Given this list of marker genes OS9, PSMB4 (NCBI Gene Id 5692), PSMD3, PSMB1, PSMD14, ADRM1, UBA52, RNF5, ERLIN2, PSMD12, PSMA2, PSMB6, PSMA4, VCP, PSMC6, PSMA5, PSMD8, ERLIN1, PSMD2, RNF185, PSMA7, PSMB7, PSMB3, PSMC1, PSMB5, PSMA6, DERL1, SEL1L, RPS27A, PSMC5, UBC, CFTR, PSMA1 (NCBI Gene Id 5682), PSMB2, PSMD1, PSMC4, PSMC2, PSMC3, PSMD6, PSMD7, PSMA3, ERLEC1, UBB, SEM1, DERL3, DERL2, PSMD13, PSMD11, here is a description of the gene set: Human Gene Set: REACTOME_DEFECTIVE_CFTR_CAUSES_CYSTIC_FIBROSIS studied in species Homo sapiens Defective CFTR causes cystic fibrosis